The following is a description of a gene set: BBSome-mediated cargo-targeting to cilium Mouse Gene Set: REACTOME_BBSOME_MEDIATED_CARGO_TARGETING_TO_CILIUM species: Mus musculus, and this is the list of marker genes: Rab3ip, Sstr3, Ttc8, Bbs2 (NCBI Gene Id 67378), Bbs5, Bbs1, Bbs9, Smo, Mchr1, Lztfl1 (leucine zipper transcription factor-like 1), Bbs7, Arl6, Bbs4